Given this list of marker genes GPR35, SMIM15, GPR108, CDS2, SPCS2, MAP1LC3A, MYOF, CNOT8, PDZD8, STK38, TSHZ1 (teashirt zinc finger homeobox 1), POLR1E, SETDB1, PHF20, ARMC7, ADGRL4, MBP, ATG101, SLC28A2, SCCPDH, C2orf68, EIF1B, POLD4, ATP6V1H, CASP8, EI24, LIMK2, BBLN, ARHGEF4, ATOSA, DMAC1, FKRP, ATRX, KLF13, ZFP36, IL18R1, EIF3A, YTHDF1, ATP11B, CPT2, ARID3B, TIMM13, PKD1, PCSK7, LNPEP, SLC37A4, IKBKE, FRRS1, LDAH, CFL1, CABLES2, PCOLCE (procollagen C-endopeptidase enhancer), SON, ARHGEF3, LIMS4, KMT2D, SEPTIN10, MDM1, SUPT5H, IER3IP1, TOMM22, ERP44, SH3TC1, PBX1, PPP1R11, FUCA1, TNFRSF18, CPSF1, CTNS, ZFP36L2, PDSS1, DPAGT1, KIAA0753, RPS6KA3, TTC39B, NUDT18, SELENOP, FAM98B, MRPL15, OGFRL1 (opioid growth factor receptor like 1), UBE3A, FOXRED2, MYCBP2, THUMPD1, PSMB10, SEC22B, AGTRAP, MDN1, SLC25A14, GPC1, ZMAT1, STAT4, SIRT7, NUDT3, CLK2, ZNRF1, KIT, NRBP1, UNC93B1, DDX54, NOB1, TLR6, BHLHE40, GM2A (NCBI Gene Id 2760), GIT2, SLC30A6, DBP, CCNY, PSME3IP1, MFSD1, PRKCI, FAM91A1, SS18L2, OSGIN1, CNOT6L, KLF10, MARVELD1, PWP1, CREB3, SLC35B2, DGAT2, WDR43, NKIRAS2, OSTM1, TRIM14, BLCAP, NAMPT, NPEPL1, ARF6, TRAF3IP3, AKR1B1, BRD3, FHOD1, ERAP1, RNF103, NPEPPS, TRMT10B, SEC63, POMP, COASY, SIPA1L1, N4BP1, LTB, AGPAT5, LXN, CSNK2B, NSMCE2, HEATR5B, ATP2B1, PLCB2, APPL2, SEC24B, MLLT6, MAP2K7, RPS11, PES1, HEATR6, ENOX2, PUS1, RPL34, TSKS (NCBI Gene Id 60385), FBXL6, BUD23, ITCH, ABHD11, PPHLN1, LDLRAD3, BANK1, CNBD2, UXS1, ING3, CCT2, DCLRE1C, SREBF1 (NCBI Gene Id 6720), ABL1, MFSD14A, SLC22A15, UPF3A, ARFIP1, HES6, UTP3, TMED9, SLC15A4, ING4, AP3S1, AGO4, DNMBP, GALNT11, EMB, ZBTB24, TMEM181, TMEM120A, CHMP7, BTNL9, PLPP6, ST8SIA6, PLEKHG2, NFIC, MYL2, AP1M1, here is a description of the gene set: Human Gene Set: GSE27786_ERYTHROBLAST_VS_MONO_MAC_DN Each fraction of mouse hematopoietic cells was purified by cell sorting from bone marrow of 8-week-old C57BL/6 mice, and its gene expression was analyzed. studied in species Homo sapiens Genes down-regulated in comparison of erythroblasts versus monocyte macrophages. from publication Konuma T, Nakamura S, Miyagi S, Negishi M, Chiba T, Oguro H, Yuan J, Mochizuki-Kashio M, Ichikawa H, Miyoshi H, Vidal M, Iwama A (PMID 21540074)